Given this list of marker genes Mup13, Strn3, Mup5, Wt1, Rragd, Clec4f, Skic2, Slc35g1 (solute carrier family 35, member G1), Dnajc5b, Kdm5b, Agfg1, Mup4, Arpc5, Lratd2, Nin, Mup7, Nup93, Tnrc6b, Mprip, Rorb, Atp11b, Wdr43, Pcmtd1, Cxxc4, Bnip3, Mup11, Zfp958, Mup14, Mup18, Ino80, Sox11, Rab8b, Sema5a, Zfp521, Nipbl, Zswim5, Twf1, Tent2, Senp1, Mup20, Cask, Ring1, Prrc2b, Phox2a, Efhc2, Sos2, Snrnp40, Ssmem1, Cggbp1, Tnfaip3, Abca1, Nrxn2, Snrpd3, Erbin, Wdfy1, Cetn3, Ythdf3, Ccdc141, Edem1, Kdm3b, Klhl2, Hnrnpa0, Smyd3, Epha7, Crh, Tfpi, Disp2, Grhl2, Slc25a32 (NCBI Gene Id 69906), Mbtps2, Matr3, Mup15, Kif1b, Ywhag, Kif3b, Gpr176, Ptpdc1, Zfp827, Mup17, Adnp, Ankrd44, Cacna1d, Cdk19, Itgal, Hacd2, Cpne8, Wnk3, Agpat5, Tet3, Abt1, Creb5, Lhfpl6, Rp2, Celf4, Nudt11, G6pc1, G3bp2, Pip5k1b, Slitrk4, Kdsr, Ric1, Zhx1, Atp2b1, Fbxo32, Bcl2l1, Onecut2, Tmem39b, Apoa5, Sv2c, Setd7, Slc14a1, Cbx5, Arhgap5, Sgpl1, Strbp, St8sia3, Tnfaip8l1, Mup2, Opn5, Setd5, Kif3a, Sat1, Mb21d2, Serpinb11, Mup10, Apln, Cd83, Pabir2, Tollip, Fut9, Shb, Dkk3, Zfp82, Has1, Smurf2, Arhgef38, Ifng, Grm5, Mup16, Mettl9, Gnrhr, Snip1, 4921536K21Rik, Appl1, Chic1, Fut8, BC016579, Dr1, here is a description of the gene set: Genes predicted to be targets of miRBase v22 microRNA mmu_miR_6416_3p in miRDB v6.0 with MirTarget v4 prediction scores > 80 (high confidence targets). Mouse Gene Set: MIR_6416_3P from publication Chen Y, Wang X (PMID 31504780) species: Mus musculus